The following is a description of a gene set: This event has been computationally inferred from an event that has been demonstrated in another species.<p>The inference is based on the homology mapping from PANTHER. Briefly, reactions for which all involved PhysicalEntities (in input, output and catalyst) have a mapped orthologue/paralogue (for complexes at least 75% of components must have a mapping) are inferred to the other species. part of: Autophagy Reactome Pathway: Macroautophagy studied in species Mus musculus electronically inferred by orthology from the curated human pathway, and this is the list of marker genes: Tubb4a, Vdac3, Tuba4a, Mfn2, Lamtor4, Tubb2b, Vim, Optn, Fundc1, Atg4d, Dynll1, Chmp2b, Mtmr14, Tuba3b, Atg7, Ube2n, Lamtor1, Atg101, Atg12, Map1lc3b, Rps27a, Lamtor5, Uvrag, Pex5, Tomm20, Tuba8, Tubb6, Ubb, Tomm5, Chmp2a, Cetn1, Csnk2b, Tomm7, Ift88, Pgam5, Mtmr3, Mterf3, Tuba1b, Wdr45b, Gabarapl2, Tuba1c, Dync1li2, Tubal3, Tomm6, Rheb, Vdac2, Gabarap, Rraga, Lamtor2, Nbr1, Prkn, Atg9b, Ube2v1, Tomm22, Atg3, Pik3c3, Sqstm1, Becn1, Tubb4b, Tsc1, Park7, Prkag1, Tuba1a, Vdac1, Rragc, Atg16l2, Pink1, Ulk1, Prkag3, Atg4c